Given this list of marker genes SAR1A, CLDN23, DMRT3, TRAV15 (NCBI Gene Id 28668), SLC44A1 (NCBI Gene Id 63942), SH3BGRL, ZNF214, ANGEL1, GUCY1A1, CFL1, BRD3OS, IKBKB-DT, SNHG12, R3HCC1L (R3H domain and coiled-coil containing 1 like), AKAP9, RBM45, EEF1G, ANO5, LINC01485, MIA2-AS1, CHCHD7, MTMR8, IL15RA, GRAMD2A, SHOX2, TMEM191A, DENND4A, GLMP, ATG12, STX16, SNAI1, ATP7A, SLC38A5, IGSF21, MORF4L1P5, TMEM98, YAP1P1, CA8, GSTCD (NCBI Gene Id 79807), INTS12, HNRNPL, LINC02390, ZNF697, LRIG3, PPP6R3, HK2, ZNF846, KRT8, NPHP3, UBR7, TRIM38, PDE11A, GPS2, ZNF608, SFT2D3, IL17RA, CCBE1 (collagen and calcium binding EGF domains 1), STX18, LINC01641, MTO1, PYGL, CHSY3, XRN2, ENSG00000187951, MIR4674, RPAIN, ABCF2 (ATP binding cassette subfamily F member 2), TYRO3, RNU6-847P, ENOPH1, KRTCAP2, MTND5P11, DTWD1, NOVA1, CBLN3, C17orf58, LINC00921, AQP4, SLC16A1-AS1, ISCA1, TRIP4, KAT6A, ELOA, ZNF852, KRT16P1, RTN1, GRWD1, HEY2, C1orf87, MTCH2, SKA3, NEXN, TRAM1, GGA1, SMG5, TWSG1, PCDHB2, DNMT1, SNORA50C, STON2, ILDR1, PBX2, PDLIM5, TARBP2, SNHG31, TEFM, RND1 (NCBI Gene Id 27289), CDKN2A, NCOA2, EMILIN2, ADAR, PPATP1, NEO1, CLDN4, CXADR, ZSCAN29, ZNF48, TRIB1, LINC01132, ZGPAT, WDR74, ENSG00000200235, CASTOR3P, SNHG7, MTOR, KRR1, PNKP, CPOX, RPL36AL, BRD9, ENHO, BATF2 (NCBI Gene Id 116071), TRPM6, PPP1R18, TTLL3, NFKBID, TUBGCP4, RNU6-1340P, STAT6, PHF12, PPP1R42, MIR4632 (NCBI Gene Id 100616438), C7orf50, NPRL3, LINC00581, NECAP2, SLC12A9-AS1, NXT1, SKIDA1, FHIP2B, RN7SL93P, SLFN12, BTBD19, TXNRD1, ANGPTL6, MIR3908, GDI2, YEATS2, H2BC18, ARPC5, MAP4K3-DT, FNBP1P1, PDE8A, NAGLU, OXCT1, SNHG11, ENSG00000235480, DDX42, SALL2, TNFAIP8, ZNF233, ZNF225, SLC7A7, ID2-AS1, RNU6-166P, TRIB3, CLN8-AS1, EIF3F, TPM4P1, PLCH2, PAXBP1, C1S, LINC00431, GGPS1, DHTKD1, ENSG00000266313, DZIP1L, AIRIM (NCBI Gene Id 54955), SRP68, ITPKA, RRP12, C6orf120, UQCRH, PKNOX2 (PBX/knotted 1 homeobox 2), LRRN4, MSC, WDR73, BTG1-DT, CLCN3, DUSP12, LACTB2-AS1, ENC1, WDR45, FES, SRSF8CP, SYNGAP1, KDM5C, PPP4R1, MOSPD1, DUS2, CCDC47 (NCBI Gene Id 57003), ITGB3, ZBTB18, TWSG1-DT, ZSCAN30, FAM21EP, RNU6-916P, SHOC2, ERMAP, HIPK1, BBLNP1, PLA2G15, MIR3912, HMG20B, ZNF148, ITGB1BP1, SNAP25, PIK3R4, ZNF687-AS1, PDS5B, UBAP2L, JOSD1, PTGFRN, CNTNAP2, TRABD2A, TTC1, RNU1-6P, RPN2, LRRC3-DT, TPM4, MTG1, NBAS, TNKS1BP1, LDLRAD4, SLC26A6, CCDC159, MRPS34, SUCLG2-DT, TYK2, UBE2L3, NEDD4 (NEDD4 E3 ubiquitin protein ligase), DNM1L, SNHG30, NDUFA12, POC1A, CHST3, GINS3, SMIM10, LINC02598, TMEM41A, CACNG8, EYA4, ERG28, WDR90, NAPSA, SRSF10, ITIH3, CHGB, ITGAL-AS1, TRMT10A, GLCCI1-DT, AP3S2, SLC38A2, LINC02240, MAN1A2, ZNF408, KIAA0586, MTTP, DCUN1D3 (defective in cullin neddylation 1 domain containing 3), MUC12-AS1, RPS27L, TRPC4, GXYLT2, TRIM14, FYTTD1, WWTR1 (NCBI Gene Id 25937), SEPTIN1, AFTPH, SKOR1-AS1, ANXA11, LRRC45 (NCBI Gene Id 201255), CNNM2, SYCE2, LINC01359, PPP1R21-DT, TOB2P1, PFAS, KDM2A, ZNF263, USP4 (ubiquitin specific peptidase 4), DYNC2I2, TGFB1, PABPN1, MRPL52, MEF2A, HEY2-AS1, TPGS1, ARHGAP1, PRDX2, COP1, PKD2L2-DT, WEE2-AS1, GLUL, ANKRD10, HDAC2-AS2, NOP14-AS1, WASHC2A, XRRA1, SCARB1 (scavenger receptor class B member 1), IKBKB, ADGRF2P, RB1CC1, PPM1B-DT, ENSG00000202059, ARFRP1, PPP3R1, MRPL41, BBIP1, ZNF581, CLPTM1L, HIPK1-AS1, NBN, NPHP3-ACAD11, CEP104, SLX9 (NCBI Gene Id 91110), RPL36P2, TNFRSF1B, RUBCN, GNAL, DOP1B, LTBP4, ZNF793, SERP1, ENSG00000283573, SMG7, RNA5SP474, CCT6B, IL16, NOVA1-DT, INPP5D, KCTD11, RNU6-386P, MAP4K5, TMEM183A, CCDC169, FLJ12825, JTB, CCNC, MAML3, CPSF3, ATF7IP, MEN1, RECQL5, FYN, MIR4510, ADAMTS1, SLC7A8, AP1S3, DNA2, TTLL13, UIMC1, MB, RN7SKP270, MAPK14, TAF1B, H4C8, DMAC2L, GABARAPL3, PPOX, RNU4-62P, RAC3, CTBP2, SPRED2, LRP1B, NEK3, RPL30P11, FABP5P3, MAST1, SOWAHC, SP1, TSC1, NLE1, SLC46A1, PHLDA1, RNU1-38P, GNA12, HMGN5, SEZ6L2, ZFAND2A, SEC22B, CD63, CIAO2A (NCBI Gene Id 84191), AURKB (NCBI Gene Id 9212), ALKBH3-AS1, LYPLA2P1, BEST3, RNU6-612P, PEX3, LRRC41, LY6G6E, RPS29P16, FASTK, FMO5, SNORA28, NLN, LINC02352, RNU1-101P, PSMC3, RPS4X, RBMS2, VOPP1, H3P44, SLC1A5, TRPC6P1, ZBTB25, MSC-AS1, DHX9, SLC9A1, ARL6IP1, AFTPH-DT, ATF7-NPFF, HELZ, C2CD5-AS1, QSER1, PNPLA7, PCLAF, IDE, MTCL1, ZNF700, BORCS6, B3GNTL1, ZCCHC2, NPRL2, PPP2R5E, TMEM19, NOP58, RUNDC3A, FAM83G, ADA, SMARCD2 (SWI/SNF related, matrix associated, actin dependent regulator of chromatin, subfamily d, member 2), ACACA, CCDC88A, ARRB2, STX4, CNR1, CCDC65, FHL1P1, INO80E, GLCCI1 (NCBI Gene Id 113263), EIF2S3, RIMS2, FSD1, CORO1C, FMN2, RERE, MIX23, PHGDH, RPL23A, SNRNP35, COIL, PSMF1, GDPD5, HEXIM1, FAM98B (NCBI Gene Id 283742), PRC1, TRAPPC9, OR1X5P, SLC30A7, TMEM101, TRMT6, HNRNPDL, CFAP298, HDHD5-AS1, CROCCP3, SCD, ENKUR, SQSTM1, ALOX12P2, PLA2G4C, ARPC4-TTLL3, DFFB (DNA fragmentation factor subunit beta), TMEM59L, PCBP1-AS1, ARRDC1, SURF1, PTGR2, ZNF675, FRG1HP, PPP2R2C, ZNF687, FGFRL1, GDF9, PPP1R21, DHDDS, LAMP1, SDC4, TBC1D7, CIAPIN1, RPL36, CCDC169-SOHLH2, OSBPL11, GIGYF2, TP53INP2, RBFOX3, NOTCH2, FCHO2, LENG8-AS1, TUBB2B, BIVM, GALNTL5, THNSL1, ARID4B, INAVA, NELFE, SEPTIN11 (NCBI Gene Id 55752), VPS50, MANEA, NRIP1, HPSE, RAD51C, PASK, SFT2D2, DLK2, ARMT1, YME1L1, CD160, PPP1R12A-AS2, LINC02848, TGFBI, AAGAB, CRYBG1, COP1-DT, RN7SKP114, TAB1, SNORD1C, HAPLN2, NCK1-DT, EXOSC2, MAIP1, SOX6, DHX8, MED21, NCK1 (NCBI Gene Id 4690), GPLD1, UBAP2, ZNF564, TNFRSF10B, HOXC4, MIR3529, NLRP14, SCG3, TRIP13, HMGCLL1, FAXDC2, NARS2, DST, SNORD42B, PPP2R1B, CHST10, SEC24B, PARP10, FRYL, CXCL16, UGDH-AS1, ZNF546, COL4A2, NLGN1, RORA, SERPINF1, PFKFB3, ACER3, SNX14, PIPOX, SOAT1, TARBP1, ROBO1, CLVS2, MAPK8IP3, RAD54B, CLHC1, ZNF324B, CDCA7P1, DSE, EDRF1, DOC2GP, SGK3, PGAM1, NIPA2, XPO7, EIF5, SNRPD1, CYB561D2, PPIAP93, MAPKAP1, SNX1, CEACAM21, RNU5B-1, EZR, RCOR1, ENSG00000265246, PRKDC, SNHG16, RAB9A, FAM13A, LRRC37B, NPAT, CEP85, NHLRC2, GTF2B, KBTBD11, RIPPLY2, PAK1, ARPC1A, CREB3L2-AS1, ZNF518A, COQ10A, TTC28, RFC4, CBX4, RNVU1-22, CHP1, TNFRSF12A, GLRX5P2, HS3ST1, MEAK7, IGSF11, TNRC6C, ARHGEF7-AS2, CFL1P1, ATAD1, EPS8, PPP1R7, SEPTIN6, SLC26A11, BBLN, DCAF4, CTNNA2, ABHD6, REXO4, PPP1R14C, AK5, USPL1, CHD9NB, DST-AS1 (NCBI Gene Id 101930585), MUC3A, KRT18P45, EBI3, VPS4B, ZNF131, YAP1, GAS8, FAM227A, LINC00466, SMARCA2, MCAM, LUZP1, JAZF1-AS1, PMM1, TMEM229B, CMKLR2-AS, MIR3162, PHLPP1, TBC1D4, COQ9 (NCBI Gene Id 57017), ZNF251, GPR32P1, EFL1, RAPGEFL1, PHB2, FRA10AC1, RPL39P18, SPTB, RMND1, UPF3AP1, MIR548AW, PHF11, MFSD10, PLAC1, ATP23, SAP130, PPM1L, SVOP, MIR4665, LIPA, MGAT4B, MAD2L1BP, RPS27P6, HEMK1, KANSL1-AS1, SCN3B (sodium voltage-gated channel beta subunit 3), WDR1, ALOX15, USP18, VPS39, IPCEF1, EIF3H, PVT1, DEPDC1B (NCBI Gene Id 94594), GCNT1, ITGB3BP, CYP1B1-AS1, MTCO3P12, NR1H3, COPS3, C4orf46P2 (NCBI Gene Id 101241901), LHFPL2, RIPOR2, GAS1, TRIM37, EDRF1-DT, LRIG3-DT, EPCIP-AS1, TXNDC11, BAZ1A, MMP16, RN7SL688P, SMG7-AS1, UTP4, ZNF286B, MDM2, TRAK2, KANSL1 (NCBI Gene Id 791085), POLI, IMPDH1, ANKRD40, MIR3611, INTS6L-AS1, RAB5C, TRIM46, MRPL57, AASDH, SNORA16A, TIMM9 (NCBI Gene Id 26520), CWC25, SLC25A39, LEF1, DNAI4, PPP1R3D, LINC01235 (NCBI Gene Id 401492), MMD, NR4A1, SLC12A9, EIF4B, NUP88, NRN1, NTAN1, SPAG7, NUCB1-AS1, FAM227B, STAT1, NDUFC2-KCTD14, RPL32P27, COMMD3-BMI1, RPS6KA2, KDELR1, CAAP1, ATP9B, ALDH1A2, MASTL, SH2B3, ADAMTSL4-AS1, ACADVL, ENSG00000233242, ZNF286A-TBC1D26, C6orf141, MTBP, TPRXL, FAM230G, ID2, DDX39A, PDZD7, PRECSIT, WASHC3, SDAD1P3, APC, ANAPC2, HOXA11-AS, FBXO38-DT, ESPN, EEF1AKMT2, WDR27, CD99, CXXC1, NUP54, NFATC4, FSCN1, SLCO2A1, SUCLG2, TMTC2, H2BC11, RNA5SP21, CBR3-AS1, FAAP100, GON4L, CMAS, ABCD3, PHF10, SMCR2, TEX14, TRIM41, RN7SL555P, RNF13, SRSF1, SULF2, GPR37, SARNP, AUTS2, COMMD3, PHRF1, WIF1, GTF2E2, SLC22A11, TCEAL8P1, LINC02985, MIRLET7I, DHRS9, UTP14A, SAXO5, PRDX1, LINC01013, GTF2I, SINHCAF, ECM1, THTPA, CCL4, DNAAF3, SCART1, XPO1 (exportin 1), INSYN2A, SYCE1L, PPP1CA, TNRC18, CALM1, ARPC4 (actin related protein 2/3 complex subunit 4), IQCH, ARIH2, ZNF286A, TFDP1, AP3S1, CNOT8, HOXC5, RUNDC3A-AS1, HMGB1, LCK, PPFIA2 (PTPRF interacting protein alpha 2), ETS2, POU4F1, TMEM216, TMEM130, PKD2L2, ARTN, NCBP2AS2, COL6A1, CATSPERG, SMG8, FBXO8, PLEKHM3, TMEM191B, NDST4, HDHD5, CDC42, CREB3L1, MLST8, EFCAB7, SSX7, ADCYAP1, PTPN2, HOMER1, TYW5, ARF4, CD101-AS1, SAXO2, CEP44, WDR31, GLG1, SURF2, MAP3K8, BRWD1, AP1S1, ZNF271P, DOT1L, MDH1B, ZNF892, NOL6, NUBP1, MOB4, SNRPC, OTUD6B-AS1, EIF4A3, RFC1, FOXP1-AS1, AGMAT, ZNF280C, RN7SL2, STRN, WNT8A, B3GALNT2 (beta-1,3-N-acetylgalactosaminyltransferase 2), SLC39A3, ARHGEF7, SGSH, ESCO2, VGLL3, SEC22A, MAL2, CEBPD, DRD4, CFAP299, BBX, SLC25A16, H2BC4 (H2B clustered histone 4), ADAM10, TRIM55, SSBP1, SNORD104, ENOX1 (ecto-NOX disulfide-thiol exchanger 1), LINC01003, TRAPPC10, DAZAP2, TRIM36, TUT1, ARAP3, KIF14, ALG14, MIRLET7IHG, CLIC5 (NCBI Gene Id 53405), ENPP5, ZC3H6, H3P10, SRRM1, JHY, RASEF, SENP8, TTF2, MANEA-DT, SMAD5, RIMKLB, NCBP2, RNU6-1003P, SCAF11, ZNF775, RIPOR1, ELOVL6, PKNOX2-DT, ZSCAN2, C7orf25, CENPV, KAT8, LIM2-AS1, MXRA7, SLC2A1-DT, GASK1A, ZNF863P, STX18-AS1, GIT2, AMPH, PSMD3, AHCYL1, PSMC2, ZKSCAN2, TAFA2, RPS7, CNNM1 (NCBI Gene Id 26507), TM2D1, FBXO38, H1-10, RCAN1, PEF1, HOXD8, COPS5P1, MYBBP1A, ZNF346, KCNN2, PLCB2, PTPN23, RTKN, PLXND1, EXD1, FRAS1, UQCC2, EIF2AK2, CDK4, MIGA1, GFI1B, LTK, MTHFD2, PRORP, LINC00240, MCM8, RRAS, KCNH3, TRIM65, PPP1R12B, USP15, RHOQ, BTG1, DZIP1 (NCBI Gene Id 22873), SCN1B, SPMIP10, NOTCH1, DYRK1A, TRIM35, HELZ2, PKNOX1 (PBX/knotted 1 homeobox 1), IMPA1, EXTL2, ANKS1A, ADAT2, LINC02576, MBTPS2, MRPL44, GMPS, HSDL2, OTUD6B, CDKN2AIPNL, ELAC2, FASTKD2, CYP2S1, SNHG25, ZNF793-AS1, FRMD7, KMT2D, NDUFS7, NR2F2, TMC6, HDAC5, HNRNPMP2, CYP2A7, FUT3 (NCBI Gene Id 2525), RYR3, INTS4, SPEG, SPCS2, ANKRD13B, HCST, MTND1P14, RDH11, TSR2, EME2, CFAP298-TCP10L, MIR4638, ITGB8, CNKSR3, ATF7, MATR3, NPM1, SNORD81, DCLRE1A, PCNP, LENG8, ASS1P5, EPCAM, TMEM191C, LRP12, THG1L, HDAC1, ZNF225-AS1, STRADB, SOX9-AS1, TRIM15, LINC01547, HEBP2, PRR14, MTFMT, ST6GALNAC3, SLC29A2, ENSG00000244137, FAM89A, CCDC40, RPL41, SLC2A1 (solute carrier family 2 member 1), STRAP, SPATS2L (spermatogenesis associated serine rich 2 like), PHLDA1-DT, SETD7, SEPTIN10, UGDH, FITM2, RSRC1, CTR9, UBTF, MIA2, COPS6, PSMB2, CCNB2, SLC16A1, HOXA9, NDUFC2, ZDHHC12, SF3A3, SLC6A1, FAM162A, DNAJC5B, SUPT5H (SPT5 homolog, DSIF elongation factor subunit), TARS2, FHAD1, KHNYN, RAB10, CAP2, ADAP2, BPNT2, MRPL48, PEF1-AS1, ASPHD1, ZFPM2, DHCR7, HUS1, APOA1-AS (NCBI Gene Id 104326055), ARMH3 (NCBI Gene Id 79591), PHF21A, STX16-NPEPL1, PDXK, ZNF462, ARHGAP31-AS1, ZFAND2A-DT, LPGAT1, ETV4, PTK2B, POGLUT2, GSE1, VPS28, MCM4, here is a description of the gene set: Genes containing one or more binding sites for (ZNF394) in their promoter regions (TSS -1000,+100 bp) as identified by GTRD version 20.06 ChIP-seq harmonization. Human Gene Set: ZNF394_TARGET_GENES studied in species Homo sapiens from publication Yevshin I, Sharipov R, Kolmykov S, Kondrakhin Y, Kolpakov F (PMID 30445619)